The following is a description of a gene set: species: Homo sapiens White color (lack of pigmentation) of the eyebrow. Human Gene Set: HP_WHITE_EYEBROW White eyebrow, and this is the list of marker genes: EDNRB, TYRP1, OCA2, SNAI2, EDN3, MC1R, MYO5A (NCBI Gene Id 4644), SOX10, PAX3, KIT, MITF